The following is a description of a gene set: species: Homo sapiens Reactome Pathway: TRAF6 mediated IRF7 activation TRAF6 is crucial for both DDX58 (RIG-I)- and IFIH1 (MDA5)-mediated antiviral responses. The absence of TRAF6 resulted in enhanced viral replication and a significant reduction in the production of type I IFNs and IL6 after infection with RNA virus. Activation of NF-kB and IRF7, but not that of IRF3, was significantly impaired during RIG-like helicases (RLHs) signaling in the absence of TRAF6. TRAF6-induced activation of IRF is likely to be specific for IRF7, while TRAF3 is thought to activate both IRF3 and IRF7. These results strongly suggest that the TRAF6- and TRAF3-dependent pathways are likely to bifurcate at mitochondrial antiviral-signaling protein MAVS (IPS-1), but to converge later at IRF7 in order to co-operatively induce sufficient production of type I IFNs during RLH signaling. part of: DDX58/IFIH1-mediated induction of interferon-alpha/beta, and this is the list of marker genes: TRAF6, CREBBP, IFNA5, IFNA17, IKBKE, TBK1, IFNA16, IFNA21, SIKE1, IFIH1, IRF3, TANK, IFNA7, IFNA4, IFNA2, IFNA1, TRAF2, IFNA13, IFNA8, RIGI, IFNB1, IFNA10, TRIM4, MAVS (NCBI Gene Id 78993), IFNA14, IRF7, RNF135, EP300, IFNA6, TRIM25